The following is a description of a gene set: species: Mus musculus Mouse Gene Set: REACTOME_G_BETA_GAMMA_SIGNALLING_THROUGH_PI3KGAMMA G beta:gamma signalling through PI3Kgamma, and this is the list of marker genes: Pik3cg, Gng10 (guanine nucleotide binding protein (G protein), gamma 10), Akt1, Gngt1, Akt2, Akt3, Gnb3, Gng2, Gng4, Gng3, Pik3r5, Pik3r6, Pdpk1, Gng5, Gng8, Gng11, Gnb4, Rhoa, Gng13, Gnb1, Gnb2, Gnb5, Gngt2, Gng7, Gng12